Given this list of marker genes NECTIN1, CDH3 (cadherin 3), TWIST1, NECTIN4, CDC45, here is a description of the gene set: species: Homo sapiens 2-4 finger cutaneous syndactyly Human Gene Set: HP_2_4_FINGER_CUTANEOUS_SYNDACTYLY A soft tissue continuity in the anteroposterior axis between the second (index) to the fourth (ring) finger that extends distally to at least the level of the proximal interphalangeal joints.